The following is a description of a gene set: studied in species Homo sapiens Platelet activation, signaling and aggregation Human Gene Set: REACTOME_PLATELET_ACTIVATION_SIGNALING_AND_AGGREGATION, and this is the list of marker genes: RARRES2, CAP1, VAV2, TRPC3, RAP1A, F13A1, LCP2, FYN, CHID1, SERPINF2, MAPK14, APP, IGF2, PDGFB, EGF, PTK2, BRPF3, FGB, LY6G6F, PRKCH, LHFPL2, GNG2, GNG5, FLNA, PIK3R3, ENDOD1, HSPA5, TGFB1, QSOX1, LYN, GNG4, RAF1 (NCBI Gene Id 5894), F2RL3, SCG3, GP1BB, RAB27B, BCAR1, APOH, GNAT3, GNG8, GNGT2, PDPK1, CDC37L1, GNB2, TOR4A, PDPN, F5, PRKCA, P2RY1, CLU, TIMP3, PPIA, YWHAZ, CALU, PRKCE, TGFB2, F2R, PECAM1, PIK3R6, GP9, F8, LCK, AAMP, F2, ADRA2C, MPL, PTPN11, RAC2, SHC1, DGKQ, ECM1, ABCC4, FERMT3, DGKI, OLA1, KNG1, SRC, ADRA2B, COL1A2, PTPN6, PIK3R1, ITPR2, IGF1, THPO, TIMP1, SERPINA1, ABHD6, PSAP, PIK3CG, ALDOA, GNAQ, RASGRP1, DGKA, CD9, ISLR, TMX3, SERPINE1, RAPGEF4, GNG10, GNAI1, STXBP3, RHOA, FAM3C, CFD, CYB5R1, MPIG6B, RASGRP2, GTPBP2, APBB1IP, MGLL, SPP2, TMSB4X, ACTN4, NHLRC2, PLG, GNG3, SPARC, GNAI2, DGKG, GNG11 (G protein subunit gamma 11), GNAI3, HABP4, PPBP, ADRA2A, STX4, GNG13, SRGN, FGA, CYRIB, ITGA2B, STXBP2, ITIH3, AKT1, GP1BA, GP6, DAGLB, TRPC6 (NCBI Gene Id 7225), SOD1, ACTN2, PLCG2, VEGFC, GNB4, DGKK, PRKCG, CLEC3B, CDC42, F2RL2, SERPINA3, MAGED2, GNA13, PHACTR2, PLA2G4A, HGF, ITGB3 (NCBI Gene Id 3690), ARRB2, GNB5, WDR1, RHOG, FCER1G, ACTN1 (actinin alpha 1), THBS1, TEX264, HRG, RAPGEF3, GNA11, P2RY12, ITIH4, TTN, ARRB1, PRKCD, CTSW, TF, CSK, VTI1B, RHOB, PLEK, DGKH, ITPR3 (inositol 1,4,5-trisphosphate receptor type 3), TUBA4A, GRB2, PIK3R5, APLP2, VEGFB, GNB1, PCDH7, LEFTY2, SELENOP, VEGFA, VWF, A1BG, ORM2, MMRN1, GAS6, CALM1, CFL1, DGKZ, ITPR1, GNGT1, CLEC1B, PIK3R2, DGKE, CD36, TGFB3, FGG, PIK3CB, SYK, SELP, LGALS3BP, MAPK3, GNA14, ORM1, SERPING1, PDGFA, VEGFD, PRKCZ, GNA15, SYTL4, LAT, MANF, PRKCB, COL1A1, CD63, PTPN1, PFN1 (profilin 1), RAC1, CD109, VCL, SOS1, GNB3, MAPK1, VAV1, PF4, ANXA5, SCCPDH, SERPINA4, A2M, PIK3CA, APOA1, GNG7, RAP1B, AHSG, ALB, VAV3, FN1, GNA12, GP5, PRKCQ, TBXA2R, ABHD12, PCYOX1L, DGKB, TRPC7, TLN1, CRK, TAGLN2, PROS1, DGKD, APOOL, GNG12, DAGLA, LAMP2